Given this list of marker genes THOC2, WNK1, IWS1, NSUN2, NEAT1, HHEX (NCBI Gene Id 5556), ALKBH5, AKAP8L, TPR, SETD2, here is a description of the gene set: Human Gene Set: GOBP_REGULATION_OF_MRNA_EXPORT_FROM_NUCLEUS studied in species Homo sapiens Any process that modulates the frequency, rate or extent of the directed movement of mRNA from the nucleus to the cytoplasm.